The following is a description of a gene set: species: Mus musculus Mouse Gene Set: GOMF_OXIDATIVE_RNA_DEMETHYLASE_ACTIVITY Catalysis of the removal of a methyl group from one or more nucleosides within a RNA molecule involving the oxidation (i.e. electron loss) of one or more atoms., and this is the list of marker genes: Fto, Alkbh3, Jmjd6, Alkbh5, Alkbh1